The following is a description of a gene set: studied in species Homo sapiens Human Gene Set: HP_CONTRACTURE_OF_THE_PROXIMAL_INTERPHALANGEAL_JOINT_OF_THE_4TH_FINGER Chronic loss of joint motion of the proximal interphalangeal joint of the 4th finger due to structural changes in non-bony tissue. That is, the PIP joint of a fourth finger is bent (flexed) and cannot be straightened actively or passively. It is thus a chronic loss of joint motion due to structural changes in muscle, tendons, ligaments, or skin that prevents normal movement. Contracture of the proximal interphalangeal joint of the 4th finger, and this is the list of marker genes: TLK2, ASXL3, ERI1, KDM5B, TBX2